Given this list of marker genes TYRP1, ADAM9, FGF1, CDH11, MFAP5, PPP2R3A, RPS7, STK17B, PLAG1, CD58, CD1B, ANXA4, GEM, RASA1, PAH, PIK3C3, SORL1, TIMP3, here is a description of the gene set: Genes down-regulated in Jurkat cells (T lymphocyte) by expression of a constitutively active form of IRF3. from publication Grandvaux N, Servant MJ, tenOever B, Sen GC, Balachandran S, Barber GN, Lin R, Hiscott J (PMID 11991981) species: Homo sapiens Human Gene Set: GRANDVAUX_IRF3_TARGETS_DN Ubiquitously expressed interferon regulatory factor 3 (IRF-3) is directly activated after virus infection and functions as a key activator of the immediate-early alpha/beta interferon (IFN) genes, as well as the RANTES chemokine gene. In the present study, a tetracycline-inducible expression system expressing a constitutively active form of IRF-3 (IRF-3 5D) was combined with DNA microarray analysis to identify target genes regulated by IRF-3. Changes in mRNA expression profiles of genes were monitored after Tet-inducible expression of IRF-3 5D. Among the genes upregulated by IRF-3 were transcripts for several known IFN-stimulated genes (ISGs). Subsequent analysis revealed that IRF-3 directly induced the expression of ISG56 in an IFN-independent manner through the IFN-stimulated responsive elements (ISREs) of the ISG56 promoter. These results demonstrate that, in addition to its role in the formation of a functional immediate-early IFN-beta enhanceosome, IRF-3 is able to discriminate among ISRE-containing genes involved in the establishment of the antiviral state as a direct response to virus infection.